Given this list of marker genes RSU1, ARHGEF6 (NCBI Gene Id 9459), ACTN1, TESK1, LIMS1, PXN, PARVA, PARVB, here is a description of the gene set: part of: Cell-extracellular matrix interactions studied in species Homo sapiens The PINCH-ILK-Parvin complexes function in transducing diverse signals from ECM to intracellular effectors. Interacting partners for components of these complexes have been identified, a number of which regulate and/or mediate its functions in cytoskeletal remodeling and cell spreading. Reactome Pathway: Regulation of cytoskeletal remodeling and cell spreading by IPP complex components